The following is a description of a gene set: Mouse Gene Set: GOBP_RESOLUTION_OF_MEIOTIC_RECOMBINATION_INTERMEDIATES species: Mus musculus The cleavage and rejoining of intermediates, such as Holliday junctions, formed during meiotic recombination to produce two intact molecules in which genetic material has been exchanged., and this is the list of marker genes: Top2a, Hfm1, Eme2, Tex11, Eme1, Ankle1, Slx4, Shoc1, Rmi1, Mlh1, Ercc4, Meiob, Cenpx, Top2b, Fancm, Mus81, Cenps